Given this list of marker genes MT-ND1, NDUFB3, NDUFAF2, NDUFA9, ATP5PB, NDUFS6, UQCRQ, WDR93 (NCBI Gene Id 56964), ATP5F1B, UQCRH, UQCRFS1P1, UQCR10, MT-ND4, COX5A, MT-ATP6, NDUFB10, COX8A, SDHA, UQCRFS1, COX7A2L, UQCR11, NDUFS7, NDUFB11, NDUFB4, NDUFB1, NDUFA5, NDUFB9, NDUFS2, MT-CO3, MT-CO1, ATP5MJ, ATP5F1C, COX5B, ATP5F1EP2, NDUFA6, NDUFB6, ATP5MC2, COX7A1, NDUFA12, NDUFA2, NDUFA4, COX6A1, ATP5MC3, NDUFB5, MT-ND2, COX6B1, COX7A2, ATP5F1E, NDUFS8, UQCRC1, COX7B, COX6C (cytochrome c oxidase subunit 6C), ATP5F1A, ATP5MG, COX8C, COX7A2P2, NDUFA11, MT-ATP8, ATP5PF, COX6A2, MTCO2P12, ATP5ME, COX7C, NDUFA10 (NCBI Gene Id 4705), NDUFA7, NDUFA13, DMAC2L, NDUFA1, ATP5PD, MT-ND3, MT-CO2, SDHB, BCS1L, ATP5MGL, NDUFC2, SDHD, NDUFA3, NDUFV1, UQCRC2, NDUFB7, NDUFA4L2, ATP5MF, ATP5PO, COX15, ATP5F1D, CYC1, COX6B2 (NCBI Gene Id 125965), COX4I1, NDUFS1, ATP5MC1, STMP1, NNT, NDUFAB1, NDUFS5, SURF1, ATP5MK, C15orf48, MT-CYB, NDUFS4, MT-ND6, SDHC, NDUFC1, NDUFB8, COX7B2, NDUFB2 (NCBI Gene Id 4708), COX4I2, UQCRB, NDUFC2-KCTD14, NDUFA8 (NADH:ubiquinone oxidoreductase subunit A8), NDUFV2, MT-ND4L, MT-ND5 (NCBI Gene Id 4540), UQCRHL, NDUFV3, NDUFS3 (NCBI Gene Id 4722), here is a description of the gene set: Any protein complex that is part of a respiratory chain. Human Gene Set: GOCC_RESPIRATORY_CHAIN_COMPLEX species: Homo sapiens